The following is a description of a gene set: Human Gene Set: REACTOME_TERMINATION_OF_TRANSLESION_DNA_SYNTHESIS Termination of translesion DNA synthesis species: Homo sapiens, and this is the list of marker genes: RFC2, POLD2, RFC1, PCLAF, UBA52, ISG15, UBE2L6, RPA1 (NCBI Gene Id 6117), UBB, UBA7, UBC, RPA2, POLE2, POLE3, POLK, POLI, RFC5 (NCBI Gene Id 5985), RPA3 (NCBI Gene Id 6119), USP43, POLD1, REV1, USP10, TRIM25, RFC3, RPS27A (NCBI Gene Id 6233), POLE, POLD3, PCNA, POLD4, POLE4, POLH, RFC4